The following is a description of a gene set: species: Mus musculus Providing the environmental signal that initiates the directed movement of a motile cell or organism towards a higher concentration of that signal. Mouse Gene Set: GOMF_CHEMOATTRACTANT_ACTIVITY, and this is the list of marker genes: Defb6 (defensin beta 6, NCBI Gene Id 116746), Defb33, Wnt5a, Fgf2, Ccl3 (C-C motif chemokine ligand 3, NCBI Gene Id 20302), Vegfa, Lgals3, Ccl9, Fgf7, Saa3, Cx3cl1, Mif, Defb46, Ccl6, S100a4, Ccl5, Vegfd, Wnt7b, Pgf, Defb48, Pdgfb, Vegfb, Hmgb2, Alkbh1, Hgf, Cxcl10, Vegfc, Colec10, S100a7a, Scg2, Ntf3, App, Ccl2, Defb3, Defb4, Defb7, Fgf8, Bmp4 (NCBI Gene Id 12159), Defb47, Defb5, Fgf10, Gm6040, Defb14, Defb8